Given this list of marker genes GIPC1 (GIPC PDZ domain containing family member 1, NCBI Gene Id 10755), IGKC, EXTL3 (exostosin like glycosyltransferase 3), CFAP410, MCIDAS, GALNS, CACNA1C, CRIPTO, PKP1, ARID1A, IL17RA, BLNK, IFIH1, RILPL1, EPM2A, FCGR2A, PAFAH1B1, HACD1, NFKB2, TGFB1, RFXANK, PNP, LTBP4, CSF2RB, KMT2D, CEBPE, USB1, DNAI1, TPM3, TCIRG1, VPS33A, ERCC6, MAN2B1, IRF1, NDUFA6, CFTR, FBLN5, RELB, KPTN, PEPD, ACP5, GATA6, FIG4 (FIG4 phosphoinositide 5-phosphatase), SCNN1A, UNC119, LAMB3, SLC25A24, PANK2, TLL1, UBB, TBCD, FCGR3B, CFB, SHH, KCNJ6, PURA, TCF3, HLA-DQB1, GFI1, ELANE (NCBI Gene Id 6417), ACADVL, CSPP1, SERPINH1, IL2RG, MARS2, EP300, AASS, ZBTB7A, NADK2, IL7R, CCDC39, CLXN, DNAI2, SMARCE1, SIAH1, TFG, CRLF1, ABCA3, NCF1, KNSTRN, MID1, NOTCH2NLC, CHD7 (chromodomain helicase DNA binding protein 7), TBX1, SYK, DOCK2, MTHFD1, CD19, ITGA7, IL6ST, TNFRSF13C, MAP3K20, PLOD1, DNMT3B (NCBI Gene Id 1789), GAS1, ACTA1, GRHL3, TIMM8A, DLL1, ZIC2, SMARCC2, FOXH1, RAC2, GLI2, DPF2, CYBC1, COL4A6, HLA-DQA1, IGLL1, SMARCB1 (SWI/SNF related, matrix associated, actin dependent regulator of chromatin, subfamily b, member 1), LAT, SREBF1, NKX2-1, MS4A1 (membrane spanning 4-domains A1), CYBB, NKX2-5 (NCBI Gene Id 1482), KDM6A, TREX1, PTEN, IGHG2, FGF8, PLCH1, AFF4, P4HTM, KIAA0586, C3, ODAD2, IFNGR1, CD3E, SMC1A, STK36, SMARCA2, CARMIL2, NCF2, NFKB1, POLA1, CITED2, TNFSF12, SIX3, RNF125, EFL1, JAK3, MYO1H (NCBI Gene Id 732239), FMO3, ICOSLG (NCBI Gene Id 23308), SFTPB, ARID2 (AT-rich interaction domain 2), RANBP2, TAF1, MEGF10, LTBP1, CYBA, PLA2G6, CD247, SNAP29, PDHA1, NFIX (NCBI Gene Id 4784), IL12RB1, IL21R, DISP1, IDH1, WDR35, DNAJC21, TNFRSF11A, ARSB, NOS1, GATA4, USP26, RNF168, PKHD1, EFEMP2, STIM1, LRBA, BLM, LEP, ASAH1, SLC35C1, FANCF, LMNB1, ALG12, PIGN, FBXW7, RAG2, RNU4ATAC, IGHM, ATP6V1B2, SMARCD1, TPM2, LRIF1, CASP8 (NCBI Gene Id 841), PIK3CD, CD81, SBDS, MRAP, RAG1, SP110, RYR1, AP3B1, MTM1 (NCBI Gene Id 4534), FOXP3, RFXAP, SOX11, SFTPC, DNAH11, EGFR, SDHD, C4B, SLC35A1, DOCK8, GAS8, POLR3A, ARID1B, WDR1, TONSL, SMARCA4, SELENON (selenoprotein N), CTLA4, NME5, STAG2, ORC6, SCNN1G, RMRP, ODAD4, ZNF699, SGCG, ATP6V0A1, COL4A5 (NCBI Gene Id 1287), FOXN1, IGBP1, GBA1, TNFRSF13B (NCBI Gene Id 23495), MED25, ZBTB24, TBX20, LAMC2, BTK, OSTM1, NBN, RFX7, MASP2, LONP1, CD27, FOCAD, TGIF1, WDR19, LTBP3, IRF8, ZNFX1, RAC1, IRF2BP2 (interferon regulatory factor 2 binding protein 2), GNPTAB, PSMB9, MYL2, PTCH1, CARD11, PMM2, ACTC1, CLPB, FGFR1, RNU4-2, DOCK11, B3GALT6, KAT6A, ODAD1, RFX5, CCDC40 (coiled-coil domain 40 molecular ruler complex subunit), PIGA, PTCD3, CD79B, CREBBP, NTRK1, HYDIN, ARPC1B, COL11A2, DDR2, SEC61A1, LAMA3, DZIP1L, LIG4, TK2, SOX4, IDS, ALMS1, REL, SRP19, CXCR4 (C-X-C motif chemokine receptor 4), MYH6, ZNF341, NIPBL, DCLRE1C, TBC1D24, NHLRC1, ADA, WAS, CAVIN1, CR2, ICOS, CDON, PGM3, SMARCD2, CD3D, DRC1, STAT3, GLB1, SAMD9, SETBP1, STIL, SCNN1B, STK4, FCHO1, DNAAF4, PIK3R1, CSF2RA, NODAL, ZAP70, LRP12, here is a description of the gene set: Inflammation of any part of the lung parenchyma. species: Homo sapiens Human Gene Set: HP_PNEUMONIA Pneumonia